Given this list of marker genes INHBA, CXCR5, EBI3, IER3, HCAR3, AQP9, EPB41L3, C15orf48, SESN2, MARCKS, IL6, CXCL3, CEMIP, CCL20, OSM, DUSP5, LAMP3, IDO1, MMP1, CCL3, SLC7A7, MTHFD1L, ATP2B1, GLYR1, CXCL1, MAP3K8, TRIB3, NAMPT, NFKBIZ, GBP1, SLC7A5, PIM2, TNF, SERPINB2, CCL4, PIM1, TNFAIP6, PARP9, TFPI2, MT1M, BATF, GNG8, C2CD4B, SOD2, VNN3P, PHGDH, ACSL1, EDN1, BCL2A1, G0S2, RGS16, AKR1C2, TRAF4, LTA, IL1B, MT1G, CSF3, CXCL5, GBP2, PYCR1, MMP14, THBD, RNF144B, CSF2, IL1A, CKB, CCL22, CXCL2, FEZ1, VPREB3, CCL1, PTX3, CHAC1, DDIT4, ADORA2A, MT2A, PTGS2, THBS1, GNG11, NEU4, SERPINB7, PHLDA2, MMP10, SERPINA1, GBP4, CXCL8 (NCBI Gene Id 3576), GBP5, IL36G, CD93, RIPK2, ABTB2, here is a description of the gene set: from publication Fletcher HA, Keyser A, Bowmaker M, Sayles PC, Kaplan G, Hussey G, Hill AV, Hanekom WA (PMID 19239680) Genes up-regulated in peripheral blood mononuclear cell stimulated vs unstimulated in infants (10w) after exposure to BCG (Danish strain BCG Statens Serum Institut, Denmark), time point 10W. Comment: PBMCs drawn at 10 weeks following immunization at birth studied in species Homo sapiens Human Gene Set: FLETCHER_PBMC_BCG_10W_INFANT_PPD_STIMULATED_VS_UNSTIMULATED_10W_UP BACKGROUND: Novel tuberculosis (TB) vaccines recently tested in humans have been designed to boost immunity induced by the current vaccine, Mycobacterium bovis Bacille Calmette-Guerin (BCG). Because BCG vaccination is used extensively in infants, this population group is likely to be the first in which efficacy trials of new vaccines will be conducted. However, our understanding of the complexity of immunity to BCG in infants is inadequate, making interpretation of vaccine-induced immune responses difficult. METHODS: To better understand BCG-induced immunity, we performed gene expression profiling in five 10-week old infants routinely vaccinated with BCG at birth. RNA was extracted from 12 hour BCG-stimulated or purified protein derivative of tuberculin (PPD)-stimulated PBMC, isolated from neonatal blood collected 10 weeks after vaccination. RNA was hybridised to the Sentrix(R) HumanRef-8 Expression BeadChip (Illumina) to measure expression of > genes. RESULTS: We found that ex vivo stimulation of PBMC with PPD and BCG induced largely similar gene expression profiles, except that BCG induced greater macrophage activation. The peroxisome proliferator-activated receptor (PPAR) signaling pathway, including PPAR-gamma, involved in activation of the alternative, anti-inflammatory macrophage response was down-regulated following stimulation with both antigens. In contrast, up-regulation of genes associated with the classic, pro-inflammatory macrophage response was noted. Further analysis revealed a decrease in the expression of cell adhesion molecules (CAMs), including integrin alpha M (ITGAM), which is known to be important for entry of mycobacteria into the macrophage. Interestingly, more leukocyte genes were down-regulated than up-regulated. CONCLUSION: Our results suggest that a combination of suppressed and up-regulated genes may be key in determining development of protective immunity to TB induced by vaccination with BCG.